Given this list of marker genes Apob, Apoc4, P4hb, Apoc1, Mttp, here is a description of the gene set: VLDL assembly studied in species Mus musculus Mouse Gene Set: REACTOME_VLDL_ASSEMBLY